The following is a description of a gene set: Human Gene Set: GSE14413_UNSTIM_VS_IFNB_STIM_NIH3T3_CELLS_UP Cytoplasmic DNA triggers the activation of the innate immune system. While downstream signaling components have been characterized, the DNA sensing components remain largely elusive. We performed a systematic proteomics screen for proteins that associate with DNA, traversed to a screen for IFN-β-induced transcripts. We identified DSIRE (DNA sensor for the IL-1β response, previously called AIM2) as a candidate cytoplasmic sensor. DSIRE showed a marked selectivity for double-stranded DNA. DSIRE can recruit the inflammasome adaptor ASC and gets redistributed to ASC speckles upon coexpression of ASC. RNAi-mediated reduction of DSIRE expression led to an impairment in IL-1β maturation. Reconstitution of unresponsive cells with DSIRE, ASC, caspase 1 and IL-1β showed that DSIRE is sufficient for inflammasome activation. Overall, our data strongly suggest that DSIRE is a cytoplasmic DNA sensor for the inflammasome. Genes up-regulated in NIH3T3 cells (fibroblast): control versus stimulated with IFN-b. from publication Bürckstümmer T, Baumann C, Blüml S, Dixit E, Dürnberger G, Jahn H, Planyavsky M, Bilban M, Colinge J, Bennett KL, Superti-Furga G (PMID 19158679) studied in species Homo sapiens, and this is the list of marker genes: RPL37, SCARF1, NAGA, SNX29, FRMPD4, RAP2A, RABIF, ID4, PXN, FBRS, ARL4A, APP, DEFB130A, LYN, TRERF1, SPNS2, MNAT1, MRPL33, KIF17 (NCBI Gene Id 57576), MUL1, LAMC1, RAMP1, RNF32, FGF13, NFATC2, HOXA5, MED8, CIZ1, PLA2G2D, MIR9-3, R3HCC1, TXNDC11, A4GALT, OAZ3, RGMB, PIGT, MED9, PDE4DIP, TLE3, ATL1, CDC42BPG, SGCZ, HSPB1, PCDH19, DNTTIP1, GATAD2B, UBTF, SDF4, UBQLN1 (NCBI Gene Id 54347), ELL2, RPL13, WDTC1, ZYX, ELAVL1 (NCBI Gene Id 1994), KCNH5, ANKRD61, ZSCAN22, HSCB, KIAA0319L, MRPS35, DUSP7, NCAM2, AXIN2, GPR151, GOLGA2, CLXN, SLC35G2, TULP2, KCNIP2, MVB12B, VPS52, OVOL3, IMMP1L, CETN3, SRGN, CRYGN, ABHD10, NMI, PRR14, CRAT, ATP13A2, RPS25, MIRLET7B, TIMM10, MYL12B, RPS27A, MIP (NCBI Gene Id 4284), ADAMTS20, ATMIN, POLR1D, PCDH12, EFCAB10, CMC1, GBF1, ELK1, LRRC7 (leucine rich repeat containing 7, NCBI Gene Id 57554), PARM1, RPP14, SPEN, RPL29, HGS, CPSF3, CPXM1, SP2, FAF2, OLFM2, DPP3, DIP2A, CHD4, KCTD12, MYOF, CDK5RAP2, SPZ1 (spermatogenic leucine zipper 1), CLCN6, CHGB, PRDX6, RAPGEF1, PROK2, HEG1, RAB11FIP5, IGLL1, CDO1, PRKAB2, TMA7, RGS9, ZC3H4, PFDN5 (prefoldin subunit 5), AQP11, TMEM128, TRIM9, RPL37A, CHRNA6, NPB, GLRX, NUP210, FECH, CNTN2, TAF3, RPL36, PTPN23, CD320